The following is a description of a gene set: This event has been computationally inferred from an event that has been demonstrated in another species.<p>The inference is based on the homology mapping from PANTHER. Briefly, reactions for which all involved PhysicalEntities (in input, output and catalyst) have a mapped orthologue/paralogue (for complexes at least 75% of components must have a mapping) are inferred to the other species. electronically inferred by orthology from the curated human pathway studied in species Mus musculus part of: mitochondrial fatty acid beta-oxidation of saturated fatty acids Reactome Pathway: Beta oxidation of palmitoyl-CoA to myristoyl-CoA, and this is the list of marker genes: Acadvl, Hadha (hydroxyacyl-CoA dehydrogenase trifunctional multienzyme complex subunit alpha)